Given this list of marker genes PALB2, NPHS2, CDKN2A (cyclin dependent kinase inhibitor 2A), NRTN, POU6F2, PML, IL10, SCN5A, APC, NR1H4, GLA, CCR1, MED12, SAA1, DMPK, UNC45A, H19, POMT1, PIK3CG, TRPC6, POLG, CFTR, MALT1, PMS2, RABL3, SLC12A3, STAT5B, TBK1, PALLD, CDKN2B, CTNNB1, IL12A, ERBB3, P4HA2, SREBF1, FSHR, HLA-DPA1, GPR35, HELLPAR, CD2AP, HEXB, GHSR, CFH, PMS1, PIK3CA, PRSS1, ELN, CASR, CORIN, EPB41, CASK, IRF2BP2, SLC25A11, EPB42, FAS, CDC73, SCN1B, NUP205, ECE1, COL4A3, CPOX, SCARB2, ABCA1, CDKN2C, TBC1D8B, GDNF, DNASE1L3, ATRX (NCBI Gene Id 6475), KCNN4, MEN1, SAT1, SPTBN1, BRCA1, TYMP, CHEK2, ALDH4A1, NUP85, NCF1, FOXP1, TRIP13, GTF2IRD1 (NCBI Gene Id 9569), MDH2, LYN, EWSR1, PAX2, PTPN3, MAX, SEMA4A, KIT, HBG2, C4A, METTL27, GTF2IRD2, BUD23, MRAP, RARA, CD46, COL4A6, HS3ST6, COQ8B, EIF4H, APRT, NUP160, TREH, MC2R, BAZ1B, ARHGAP24, GPC3, KRAS, ANKFY1, TP53, CARD8, IKZF1, CLPB, PORCN, SDHA, BIRC3, SERPING1 (serpin family G member 1), BMP2, TGFBR2, KLRC4, DAAM2, ALAD, MYC (MYC proto-oncogene, bHLH transcription factor), CFI, PTPRO, IRAK1, CTLA4, MVK, GOSR2, SEMA3C, ANLN, MET, IL6, EMP2 (NCBI Gene Id 2013, epithelial membrane protein 2), ELF4, DLST, PIGY, TXNRD2, RBCK1, CTRC, CD55, CEL (carboxyl ester lipase), BMPR1A, RRM2B, PIGA, APOL1, MAGI2, BCOR, F5, CLIP2, ROS1, ABCG8, PRTN3, TET2, CRB2, G6PD (glucose-6-phosphate dehydrogenase), GAPVD1, UBAC2, IFNGR1, MSH2, HBB, RIPK1, GFI1, SEC63, TMEM270, ATP7A, PRKAR1A, SPTB, PTPN22, SYK, ASXL1, NLRP3, MIF, ATM, NPHS1, SPINK1, GYPC, CPA1, ABCB11, SMO, LRP5, CLCNKB, SOX10, NUP93, RUNX1, NNT, ERAP1, HLA-DQB1, KLF1, ATP8B1, GUCY2C, SEMA3D, DIS3L2, STAT3, OTC, ABCB4, HLA-DQA1, EPCAM, TLR4, PRKCSH, GCGR, EDN3, NLRP12, TRPM4, CDKN1A, DDIT3, ABCC2, NKX2-5, OPLAH, GNE, MUTYH, SEMA4D, HLA-DRB1, LIMK1, TMEM127, HFE, TSC2, GNA11, ESR1, PKHD1, TBL1XR1, ABCD1, STX1A, SRP19, ZNRF3, F12, BCL11A, PIEZO1, NCF4, CNBP (CCHC-type zinc finger nucleic acid binding protein), RPS20, RET, BCL10, FLT1, CCND1, CPT2, NUP107, PRSS2, MEFV, ACTG2, VPS37D, NUMA1, SRSF2, STK11, HPS1, GBA1 (glucosylceramidase beta 1), HLA-DPB1, KIF1B, TCIRG1, IL23R, REST, TSC1 (NCBI Gene Id 7248), STAR, DNMT3A, IRF4, HBG1, STAT4, EPOR, CDKN1B, ANK1, TBL2, NABP1, SPP1, INF2, SDHB, FIP1L1, ATP7B, RAD21, SI, WT1, CBL (NCBI Gene Id 867), HMBS, POLE, EDNRB, NUP133, ZBTB16, SDHD, TRIM28, TERT, DNAJC30, FUS, POLD1, NF1, OTULIN, SLC25A26, UQCRH (ubiquinol-cytochrome c reductase hinge protein), MLH1, ALDOB, FLI1, MYO1E, CLDN16 (NCBI Gene Id 107986170), TNFRSF1A, TRPV6, DGAT1, MITF, COL4A5, TCF4, NPM1, SPTA1, NOD2 (nucleotide binding oligomerization domain containing 2), IL12A-AS1, RNF168, MST1, NUP37, PNPT1, SDHC, EPAS1, MMUT, STOX1, ARHGDIA, MNX1, PTEN, VHL, MLYCD (NCBI Gene Id 23417, malonyl-CoA decarboxylase), JAK2, FH, RFC2, LIG3, MCM6, ERBB2, FGF13, ADA2, SDHAF2, FKBP6, CEBPE, CALR, HLA-B, PIGT, ELANE, SMAD4, BMP6, PLCE1, GTF2I, MSH6, LPL, SLC4A1, LACC1, ACTN4, BRCA2, PPOX, here is a description of the gene set: species: Homo sapiens Human Gene Set: HP_ABDOMINAL_PAIN An unpleasant sensation characterized by physical discomfort (such as pricking, throbbing, or aching) and perceived to originate in the abdomen. Abdominal pain